Given this list of marker genes Eva1a, Gata4, Rock1, Ppp3ca, Timp1, Ugt1a1, Rock2, F2r, Il1a, Umod, Fam114a1, Pparg, BC004004, Hif1a, Klf6, Fkrp, Lrrc25, Clec10a, here is a description of the gene set: The series of events leading to growth of connective tissue when loss of tissues that are incapable of regeneration occurs, or when fibrinous exudate cannot be adequately cleared. Mouse Gene Set: GOBP_CONNECTIVE_TISSUE_REPLACEMENT species: Mus musculus